The following is a description of a gene set: species: Mus musculus Mouse Gene Set: chrYC3, and this is the list of marker genes: Gm20870 (predicted gene, 20870), Gm20908, Gm29634, Gm29002, Gm28253, Gm20932, Gm21877, Gm28835, Gm28589, Gm33815, Gm20803, Gm28859, Gm21895, Gm29377 (NCBI Gene Id 102631700), Gm20907, Gm29546, Gm28255, Gm20823, Gm29633, Gm20843, Gm29637, Gm21672, Gm28844, Gm20933, Gm20935, Gm29058, Gm21114, Gm20869, 4932431L22Rik, Gm21127, Gm21634, Gm28133, Gm29639, Gm21627, Gm20888, Gm29062, Gm21826, Gm20885, Gm21530, Gm29586, Gm21151, Gm21617, Gm20866, Gm20817, Gm29424, Gm20818, Gm21160 (predicted gene, 21160), Gm29545, Gm28302, Gm20924, Gm28637, Gm21654, Gm28136, Gm20886, Gm21880, Ssty2, Gm28795, Gm20804, Gm28837, Gm28843, Gm28185, Gm21171 (predicted gene, 21171), Gm20936, Gm20874, Gm20868, Gm29179, Gm21794, Gm21808, Gm20736, Gm29452, Gm21518, Gm21118, Gm21910, Gm29181, Gm28749, Gm28990, Gm28079, Gm20937, Gm20921, Gm29624, Gm29003, Gm28598, Gm21806, Gm29420, Gm29061, Gm20842, Gm28446, Gm28840 (predicted gene 28840), Gm29659, Gm28462, Gm28646, Gm29000, Gm29218, Gm20934, Gm20816, Gm28819, Gm20852, Gm20882, Gm28480, Gm21524